Given this list of marker genes DNM3, DIP2B, TTC39B, FSD1L, TNFAIP8 (TNF alpha induced protein 8), DLGAP1, NUS1, FGF12, JAG1, CBFB (NCBI Gene Id 9163), FN1, PTPN22, ZNF648, RAB8B, SMC5, ACOD1, FNDC3A, TIPARP, ATP11C, ARID2, EIF5B, SCFD2, TEX10, FZD6, KATNAL1, ITM2B (integral membrane protein 2B), RAP2C, SLC30A7, CCNY, IGF1, TET1, SYT4, RAB6B, UBQLN2 (NCBI Gene Id 29978), PRRC2C (proline rich coiled-coil 2C), SUCO, PLSCR4, BANK1, NEK7, TIAL1 (NCBI Gene Id 8430), ZSWIM2, PLSCR1, MEDAG, ESM1, KALRN, FLT1 (fms related receptor tyrosine kinase 1), FUT9, SOX6, DTHD1, SRRM4, DFFB, ZDHHC21, TDRD15, CNTNAP3B, MTMR2, CBX3, ARL5B, GNA13, DUSP12, SLC18A2, BCL7B, NRG3, ERCC6L2, FOXF1, DMD, TRAK1 (trafficking kinesin protein 1), MBTD1, PCDH15, POGK, CHEK1, SHMT1, KCNC2, AEBP2, MTX3, SPIRE1, SPRY2, ARHGAP19, THAP6, TRIM71, BLOC1S6 (NCBI Gene Id 26258), GABRA2, ARHGEF12, SP8, LMO7, LY75-CD302, PDIK1L, TRMT61B, PAQR5, COMMD2, ZIC2, BICC1, CCDC71L, SYPL2, SMAD5, ZNF711, ZNF449, PNPLA4, SANBR, THSD7A, DCUN1D3, ZNF384, CCDC34, FAM13B, CHUK, ZC3H11A, NLRC3 (NLR family CARD domain containing 3), CEACAM8, TENM1 (NCBI Gene Id 10405), ALAD, MSX1, UBE4A, KLHL9, UBLCP1, IFNG, CASK, LHCGR, TRPA1 (transient receptor potential cation channel subfamily A member 1), FAM124A, DCX, SPRED1, FAXC, MDM4, SOX2, IGF2BP3, C1orf56, ONECUT1, RAB3C, SPATA22, APOOL, LIN7A, ZNF546, RAN, NIPSNAP3B, HK2, FAM13C, PRPF38B, JMY, POU2F1, ATP7A, SLC35F3, TLK2, SGTB, PSMD11, RNF4, MYO1D, PRTG, POLR2M, HTR1F, MKRN1, GTF2I, ARHGAP5, E2F6, RALBP1, PTGER2, STOML2, PIP4P2, LTN1, TTC33, GOSR2 (golgi SNAP receptor complex member 2), TMEM106B, SSMEM1, BMPR2, TMEFF2, NDUFA5, PROX1, PDE7A, DCUN1D4, ZNF451, CCZ1B, PABIR2, ALG10B, HMGB1, TGFBR1, AFDN, NEK1 (NIMA related kinase 1), NINL (NCBI Gene Id 80250), CRYZL1, KCNG3, NIPSNAP3A, KCNQ5, SMARCAD1, ERC2, MARCHF7, STOX2, KRBOX5, WASF1, ZNF280B, TMEM165, GUCY1A2, API5, ADAT2, BRI3, CLDN22, THAP2, C2CD6, REEP3, ELK4, YAE1, RLIM, CHORDC1, TMED7, TMEM38B, TNRC6B, FUT10, SPDYE3, MAPKAP1, CCNYL1, STX12, SEMA3D, DPP10, PRR32, ATP11A, ZXDC, CFTR, ZMYM2, XPOT, CNST, PTPN4, ZDHHC14, ARF6, SPOCK3, EIF1AX, LRP11, METAP1, CNOT8, FSIP1, SHROOM4, ZNF250, RABGEF1, INTS13, DDX5, OSBPL8, RNF38, TMEM33, LHFPL6, LRP2BP, ZEB2, IPO11 (NCBI Gene Id 51194), GTF2H3, CRLF3, MID2, GSPT2, RORA (NCBI Gene Id 6095), MAGI3, CCDC141, RAB2A, UNC5D, HSPA13, USP9Y, CXCL8, GLRB, RALGPS2, CHKA, NR4A3 (NCBI Gene Id 8013), RCBTB1, MAN1A1, DDHD1, SPATA13, SLC1A4, MIER1, PGAP2 (post-GPI attachment to proteins 2), NAB1, DYNC1I1, NR1D2, NSUN6, CREBZF, GEM, PABPC4L, EXOC5, TRPC5, CERS3, PPP2R2A, BIRC6, ZBTB21, ITGAV, DKK2, ST8SIA4, TMPRSS4, MDGA2, ACER3, HDAC9, ZCCHC10, JRKL, SLC1A2, GPHN, PTBP3, PRKG1 (NCBI Gene Id 5592), GSKIP, CYP2U1, ST3GAL5, MOSPD1, SLC2A2, EPHA5, ITPRID2, CDK13, ANKRD17, GOLGA3, SUZ12, TYW5, ARFGAP3, HOXD8, PACSIN2, HNRNPR, TRIM5, ZBTB41, IGIP, IKBIP, SERINC1, FAF2, CDC37L1, GNE, CD302, SFMBT2, FAM110B, ATXN3, RAPGEF6, PAPOLG, PSG1, PPM1B, SLC38A4, LCOR, GABRA4, PKN2, LRCH2, COX5A, TM9SF1, CEACAM5, PRRC2B, FAM169A, RIMS2, PSMD14, MSI1, RBBP6, AP1AR, TLCD4, EGF, CREB5, SRSF10, ICE2, STK32B, KCNT2, FGF7, EIF5A, OPRM1, ARX, DOCK10, GFPT1, WBP2, PDHB, TDRD6, ROBO1, REPS2, ANGPT1, ARL5A, USP1, NRBF2, AKAP11, DHX15, CCDC121, CSN2, TRPC1, LRP6, RFX3, DOCK5, CCNT2, HOXA7, SHISA9, FAM120A, SELENOI, DIPK2A, RBMS3, ABCC4, TNRC6A, LZIC, SEC23A, ANKRD44, DISC1 (DISC1 scaffold protein), EPB41L2, CREM, C8orf34, DNAJC3, IRX2, RAG1, DCAF8L1, FBXO11, GPC6, TM7SF3, GJB2, PHF12, ACVR2A, S100PBP (NCBI Gene Id 64766), EOGT, CLCN6, ZNF45, TSFM, SEMA3A, TOX, PCDH19, TLR7, MTMR9, PI15, ZC2HC1A, DPP8, SLK, LRCH1, AK7, EIF4A2, MAP9, EIF2S1, USH2A, POGLUT1, PPP3R1, TDRD3, REEP1, PIK3CA, ARHGAP32, FMR1, XKR9, TCTN1, IVNS1ABP, ATP5F1C, TMEM26, CPSF6, MMRN1, CNOT6 (NCBI Gene Id 60404), ATXN7, TMEM192, TMED4, DICER1, SCCPDH, CDIN1, ZC3H12C, TENT5A, CUL4B, CHIC1, STT3B, AHR, STXBP5, PCDH20, SGPP1, MB21D2, ZCCHC12, CAST, KIAA1210, PHTF2, SORL1, SCAI, MGAT4A, UBASH3B (ubiquitin associated and SH3 domain containing B), MAD2L1, IGSF8, ATP13A3, PRDM1, PRP4K, PRKACA, GSPT1, ZBTB33, CHM, AGAP1, KLHL28, CLVS2, PALS1, SLC16A1, AAK1, ACAP2, GOLIM4, ACKR3, NAA50, ERF, ZNF354C, FYTTD1, WDR17, MMP16, NUAK1, ARHGAP42, FAM168B, YWHAZ, CACNA1B, PGRMC2, C2orf68, LYPLA1, BDP1, SPAG6, UFL1, SLC1A3, SARAF, SLC66A1LP, LYSMD3, VEZT, SUCLA2, RASA2, CADM2, MAP3K2, HECA, ITGB8, TSPAN13, KLF12, SLC25A25, MAP1B, LYPLAL1, GGCX, MCTP2, SI, TSPAN12, ACSL4, PDLIM5, GDA, GJA1, CWC22, TECRL, ADD3, MYMX, HOXD3, SLC16A7, ATG4A, GNB5, RNF7 (NCBI Gene Id 9616), PDXDC1, KCTD6, GPR37, LGALS8, CPNE3, PARP8, LMAN1, KLHL31, NCKAP1, DNAJC12, BOD1L2, C14orf39, VCF1, KCNQ3, MORN2 (MORN repeat containing 2), IQGAP2, PTPN12, PGM2L1, ZCCHC2, MARK1, NAA30, ABHD13, TMF1 (NCBI Gene Id 7110), HEMGN, PDK3, AFF4 (ALF transcription elongation factor 4), NMBR, F13B, WASHC4, C2orf88, HOXA3, TDG, MAP3K7, RAB12, ZNF527, BNIP2, NPM1 (nucleophosmin 1), RIF1, DENND5B, BTLA (NCBI Gene Id 151888), ZNF770, CDKN2AIP, CXCL14, SNTG1, SUPT3H, IMPA1, PRKACB (NCBI Gene Id 5567), MAB21L1, TRAPPC13, CNTN1, TAF5L, BACE2 (NCBI Gene Id 25825, beta-secretase 2), PCMTD1, ZNF518A, MAP3K1, INSM1, COL11A1, TRIP12, KLF6, PLCB1, ABCC10, USP54, YPEL5, PAX5, MPP4, MCC, NIBAN1, HOOK1, DENND1B, SMAD2, TPRX1, CT45A1, COL12A1, FBLN5, TPGS2, RUBCNL, BLOC1S5, EDNRA, TMEM59, SLC25A24, KIF21A, MARF1, ZFC3H1, FSD2, PTPDC1, DNAJC9, GPM6A, ZPBP, GPR88, MIGA1, ZNF827, IYD, AMD1, FBXL17 (NCBI Gene Id 64839), CLPX, FAM114A2, NECAP1, ZCRB1, VGLL3, BRWD3, RC3H1, TARDBP, SP1, DMXL1, CACNA2D1, SYNRG, HS3ST5, TMEM229A, ACTR3, PDE1C, EIF3A, ELAVL2, SPATS2L, ZNF284, NUFIP2, EPHA7, ERAP2, DTL, ANK2, TRA2A, UBXN2B, GCOM1, BNIP3L, TBC1D1, here is a description of the gene set: Human Gene Set: MIR3671 from publication Chen Y, Wang X (PMID 31504780) Genes predicted to be targets of miRBase v22 microRNA hsa-miR-3671 in miRDB v6.0 with MirTarget v4 prediction scores > 80 (high confidence targets). species: Homo sapiens